The following is a description of a gene set: from publication Marzec M, Halasa K, Kasprzycka M, Wysocka M, Liu X, Tobias JW, Baldwin D, Zhang Q, Odum N, Rook AH, Wasik MA (PMID 18281483) In this study we compared the effects of IL-2, IL-15, and IL-21 on the gene expression, activation of cell signaling pathways, and functional properties of cells derived from the CD4+ cutaneous T-cell lymphoma (CTCL). Whereas both IL-2 and IL-15 that signal through receptors that share the common gamma chain and the beta chain modulated the expression of >genes, IL-21 that signals via the receptor also containing gamma chain up-regulated <genes. All three cytokines induced tyrosine phosphorylation of Jak1 and Jak3. However, only IL-2 and IL-15 strongly activated STAT5, PI3K/Akt, and MEK/ERK signaling pathways. In contrast, IL-21 selectively activated STAT3. Whereas all three cytokines protected CTCL cells from apoptosis, only IL-2 and IL-15 promoted their proliferation. The effects of the cytokine stimulation were Jak3- and Jak1-kinase dependent. These findings document the vastly different impact of IL-2 and IL-15 vs. IL-21 on malignant CD4+ T cells. They also suggest two novel therapeutic approaches to CTCL and, possibly, other CD4+ T cell lymphomas: inhibition of the Jak1/Jak3 kinase complex and, given the known strong immunostimulatory properties of IL-21 on CD8+ T, NK, and B cells, application of this cytokine to boost an immune response against malignant CD4+ T cells. Genes down-regulated in Sez-2 cells (T cell lymphoma): untreated versus IL5. species: Homo sapiens Human Gene Set: GSE8685_IL2_STARVED_VS_IL15_ACT_IL2_STARVED_CD4_TCELL_DN, and this is the list of marker genes: TOMM70, CUL1, ZNF703, NBEAL2, YPEL1, NDUFB9, OSBPL1A, CXCR3, XRCC2, VSIG10, IKZF1 (NCBI Gene Id 55429), TRAPPC8, ANKRD28, CTNND1, THOP1, ITPK1, MARVELD2, CTPS1, IKBIP, PHKA1, KIT, TCEAL8 (NCBI Gene Id 92220), UBE2D2, ZNF397, ELK3, MXD3, ZFHX3, MTMR14, REEP4, TPD52L2, CX3CR1, SLC22A15, TNFSF10, RPL13, ADAM9 (ADAM metallopeptidase domain 9), NAT8, SSRP1, CPLX1 (complexin 1), DACT3, USP1, NSD2, ADAM10, ZDHHC24, FAM53C, ELMO2, CAPN15, COL6A3, CYP2C8, ROCK1, WDTC1, NUP133, OGFRL1, ABHD1, JPH1, IL36RN, ESCO2, MYO1H, CIAPIN1, ZNF707, TOPORS, RAP2A, ATP5ME, ZMIZ1, EPHB3, HNRNPA0 (NCBI Gene Id 10949), MCRIP1, BUB3, CKAP2, SNED1, ACOT4, PRG3 (proteoglycan 3, pro eosinophil major basic protein 2), CRIM1, RPL36, KRTAP2-4, NCSTN, MYO1E, H2AB2, TIMP4, CD84, SYMPK, PKP2 (NCBI Gene Id 93271), CSRP1, GLB1, MDH2, EBAG9, RXRA, SPO11, PFAS, WDR81, SLC35B4, PIGB, SLC25A3, MTUS2, PTK2B, SCNN1A, ZCCHC18, EML3, PKMYT1, NBAS, MS4A2, ARRDC4, TAOK2, SLC39A1, BTBD9, SLC23A1, BTF3, INTS15, ARMCX2, TPK1, C19orf47, SERTAD4, CSF2RA, CSF2, ZAP70, INO80D, COQ4, GOLM1, PTPN18, NCOA1, MYBL1, INHBA, BSG, C1orf174, TIMM17B, FBXW8, CHCHD7 (coiled-coil-helix-coiled-coil-helix domain containing 7), GSK3A, TMEM131L, DIAPH2, DTX2, ANAPC2, GSS, MAGEA11, CCHCR1, MDM1, GAA, RGS19, AP2A1, FBXO30, MLKL, SH2D2A, POGLUT3, TRIM14, NR3C1, GALNT4, PDLIM7, RAC3, ANKRD13B, CHRM3, NCBP2, RHOC, PIK3R1, DSE, H2AJ, CIRBP, ZFP41, CLN3, USP14, RAB6A, CARM1, TBC1D12, GPSM2, MUTYH, ZNF628, STYK1, TWF2, RNF208, HROB, DHFR, GJB6, NEO1, DZANK1, STK35, UCK2, LUC7L3, NKAP, ZNF324B, HNRNPA3, ABI2, TTC8, CMYA5, TTC7B, TBL1XR1, SLC66A3, TPM3, COCH, HPS4, GTF2IRD2, OTUB1, ZNF341, WDR53, CTC1, AFMID, DOK2 (docking protein 2), NFKBIE, PAM, LRRC40, TTC9C, RAD51B, CDC42BPG